The following is a description of a gene set: from publication Chen Y, Wang X (PMID 31504780) Mouse Gene Set: MIR_19A_3P studied in species Mus musculus Genes predicted to be targets of miRBase v22 microRNA mmu_miR_19a_3p in miRDB v6.0 with MirTarget v4 prediction scores > 80 (high confidence targets)., and this is the list of marker genes: Skida1, Rgl1, Npepl1, Sephs2, Pcdhac2, Mtcl2, Brwd3, Cyp2c50, Ccm2, Pcdha4, Zdhhc18, Fbxo48, Rap1a, Fastk, Zbtb18, Plxna4 (plexin A4), Atp10a, Nufip2 (NCBI Gene Id 78671), Ccnl1, Suz12, Kcna4, Zfp563, Dgke, Ppara (NCBI Gene Id 399624), Mical3 (NCBI Gene Id 194404), Ldoc1, Pcdh10, Cbx7, Spryd3, Pou3f2, Ebf2, Slc9a1, Tfcp2l1, Taf4, Med26, Tmem47, Nfib, Phlda3, Tbk1, Pdik1l, Cab39, Abr, Rap1b, Cand1, Spire1, Fut9, Arhgap11a, Scd1, Mctp1, Eogt, Sulf1, Cltc, Zfp992, Garem1, Edaradd, Rnf11, Tnfrsf12a, Mosmo, Nrk, Enc1, Tm6sf1, Ccnd2, Ppp2r5e, F3, Adcy9, Impdh1, Ivns1abp, Atp2c1, Ino80, Wnk1, Slc24a3, Rimkla, Kpna6, Btf3l4, Bnc2, Tmem65, Khdc4, Slc4a7, Mylip, Pcdha6 (protocadherin alpha 6), Slc5a7, Mab21l2, Fam162a, Pou4f1, Dnai1, Sebox, Adrb1, Akr1c14, Stox2, Zfp521, Med13, Slc6a8, Bambi, Acadm, Prickle2, Fndc3a, Map3k2, Rhebl1, AI987944, Mef2a, Cacna1c, Phtf2, Pcsk5, Dock4, Sh3d19, Dnaaf9, Pclo, Tmem250, Arfip1, Robo2, Tor1b, Acsl4, Vti1a, Clock, Scn1b, Mb21d2, Smarca2, Castor2, Wasl, Tnrc6b, Abca1, Rtn1, Atg14, Pptc7, Ddx3x, Fbxl4, Acsl1, Rnf111, Fam83d, Slc35f1, Abhd17c, G3bp2, Gtf2h1, Mfsd6, Med12l (NCBI Gene Id 99835), Ndfip2, Tmem64, Get3, Zfp973, Relch, Hprt1, Vcf1, 3830403N18Rik, Tet3, Memo1, Car8, Arfgef1, Pcdha1 (NCBI Gene Id 116731), Atl2, Clip1, Tspan2, Cnot4, Mbd6, Syt11, Dnajc24 (NCBI Gene Id 99349), Foxp1, Atg16l1, Sgk1, Mphosph9, Coq10b, Prdm1, Slc9a6, Pde5a, Phf13, Klhl20, Zfp654, Cblb, Txlng, Tnks, Mycn, Wac, Pcdha2, Jade1, Epgn, Etl4, Ephb3, B230219D22Rik, Adcy1, Rest, Sdc1, Mllt6, Ccdc126, Igsf3, Sin3b (transcriptional regulator, SIN3B (yeast)), Qki, Rnase2a, Rhob, Hipk3, Magi2, Cbln2, Emx2, Cast, Lonrf1, Plcb1, Hbs1l, Rnf216, Zc2hc1a (NCBI Gene Id 99818), Asxl2, Atxn7, Snx17, Stat2, Card10, Mbnl3, Cep170, Fhip1a, Rapgef2, Cul5, Desi2, Wdr26, Adss2, Rab33b, Ddhd2, B3galnt2, Mapk6, Itga6, Arap2, Id2, Xlr, Pik3ca, Sec63, Tbrg4, Chmp1a, Eeig1, Igfbp3, Plxnc1, Hbp1, Mmgt1, Ldaf1, Sh3rf3, Fzd4, Tgif1, Clvs2, Zfp827, Skil, Jazf1, Arc, Siva1, S1pr1, Prc1, Atxn1l, Zfp367, Cntfr, Retreg1, Bmpr2, Cyb561d1, Cdkal1, Dock10, Npas2, Fam43a, Zfyve26, Socs3, Klf13, Gigyf1, Wdr44, Smoc1, Mier3, Agbl3, Slc35a5, Rufy3, Tab3, Tbc1d8, Myh11, Lrp2, Zmynd11, Ankib1, Otud1, Rassf2 (NCBI Gene Id 99374), Appl1, Tnrc6c, Zbtb4, Fbxo32, Dtna, Elmod2 (ELMO/CED-12 domain containing 2), Arrdc3, Zfp965, Ube2d2a (ubiquitin-conjugating enzyme E2D 2A), 2510039O18Rik, Lin9, Raf1, Dlx1, Syt1 (NCBI Gene Id 20979), Rora, Lrch1, Kcnj2, Kif3a, Bet1l, Ell2, Wdr45b (WD repeat domain 45B), Rabepk, Nrbp1, Mpped2, Btbd7, Fmr1, Cdk19, Elavl4, Bhlhe23, Ubl3, Hecw2, Fras1, Kbtbd8, Pnrc1, Slmap, Pcdha11, Cldn34c1, Dicer1, Ice2, Lrig1, Dipk1a, Elovl5, Etv1, Ube2d3, Socs1, Tshz3, Miga2, Usp32, Zfp831, Dsel, Rnf167, Chst1, Tbc1d12, Igf2r, Adamts7, Eif4a2, Bend3, Rbbp8, Sox6, Cnksr2, Sowahb, Hnrnpul2, Prune2, Fam83g, Clip4, Armc8, Rap2c, Adipor2, Or10d5j, Zbtb10, Togaram1, Arhgap12 (Rho GTPase activating protein 12), Rbms1, Asap2, Prr5l, Kcnc4, Ddx3y, Klf10, Esr1, Pak6, Gpr137b, Ccdc88a, Zfp91, St8sia3, Chl1, Pcdhac1, Nipa2, Cgn, Pcdha5, Ube2a, Adgrl2, Rin2, Dpysl5, Pcdha8, Sec11a, Aldh3a2, Arpp19, Tsc1, Vps4b, Wnt7b, Rbms3, Slc26a7, Llgl2, Otud7b, E2f8, Nfia, Rab8b, Dcun1d3 (defective in cullin neddylation 1 domain containing 3, NCBI Gene Id 72260), Ccser2, Arrdc4, Sel1l3, Map3k12, Pcdha10, Ttc9, Mecom (MDS1 and EVI1 complex locus), Usp33, Mbnl2, Pcdha3, Npas3, Phf12, Pcdha9, Fosl1 (fos-like antigen 1), Rfx4 (regulatory factor X, 4 (influences HLA class II expression)), Patl1, Dock3, Ark2n, Hic1, Psap, Zfp711, Fam168a, Nlk, Srsf6, Fbxo8, Sybu, Lsm12, Tgm3, Nmt2, Rab18, Pcdha12, Mdfic, Pik3cb, Tnfaip3, Plaa, Usp8, B4galt5, Mtmr10, Zfp609, Prrt3, Snx25, Cc2d1a, Hhip, Prkaa1, Kcne2, Arhgap21, Cnot6, Sema4c (NCBI Gene Id 98332), Ano1, Vps37a, Macf1, Csmd1, Gpcpd1, Zmat3, Kdm2a, Atf2, Bcl2l11, Cacul1, Zfp516, Acbd5, Gpr137c, Zfp518a, Klf9, Flnc, Dmxl2, Znrf3, Camsap1, Kpna3, Slc31a2, Stk35, Ankrd29, Ccl11, Adcy7, Zfp385b, Gm11437, Itch, Gtf2a1, Pknox1, Psd3, Gpr155, Vstm2b, Grk6, Pdf, Klhl42, Atxn1, C87436, Taok1, Shank1, Pik3r3 (NCBI Gene Id 99994), Wdr1 (WD repeat domain 1), Marchf2, Nbeal2, Fam114a1, Vamp3, Smurf1, Chic1, Pgm2l1 (phosphoglucomutase 2-like 1), Ppp2r3d, Wbp1l, Btaf1, Crebrf, Wdfy3, Pitx1 (NCBI Gene Id 18740, paired-like homeodomain transcription factor 1), Mycl, Sbf2, Epn2, Mapk1, Pmepa1, Rsbn1l, Sipa1l1, Nhsl1, Nr3c2, Reep3, Pcdha7, Grsf1, Cnot6l, Zfand5, Trim33 (tripartite motif-containing 33), Gulp1, Smad5 (SMAD family member 5), Tub, Mastl